The following is a description of a gene set: Pathway Definition from KEGG: TP53* // (CDKN1A,GADD45,BAX,BAK1,DDB2,POLK) Human Gene Set: KEGG_MEDICUS_VARIANT_MUTATION_INACTIVATED_TP53_TO_TRANSCRIPTION species: Homo sapiens Mutation-inactivated TP53 to transcription. Pathway ID: N00115. Pathway type: Variant. Pathway class: nt06260 Colorectal cancer., and this is the list of marker genes: BAK1, GADD45G, TP53, POLK, GADD45B, BAX, DDB2, GADD45A, CDKN1A